Given this list of marker genes Rack1, Mfsd4b1, Ap2a2, Aplp2, Rplp1, Acsl5 (NCBI Gene Id 71879), Lmo4, Flvcr1, Lgals3, H2aj, Rpl39, Actn4 (actinin alpha 4), Dynlt3, Tomm6, Pdia3, Pth1r, Tmem176a, Rps19, Ptprf, Adgrg1, C130074G19Rik (NCBI Gene Id 226777), Ube2d3, Cyfip2, Rpl12, Fth1 (NCBI Gene Id 14319), Fgf1, Pgk1, Rpl31-ps12, Rpl5, Gng12, Hoxb9, Pdcd4, Stat3, Wsb1, Bmp4, Pmepa1, Mal (myelin and lymphocyte protein, T cell differentiation protein), H2-K1, Tmbim6, Serp1, Foxq1, Pdia6, Dstn, Sh3bgrl3, Eva1b, Atp6v0a4, Entpd4, Rbm47, Spink1, Actb, Gls, Mfge8, Ly6c1, Tmem178, Gas6, Dynll1, Bbln, Ggt1, Tmprss2, Arpc2, Tle5, Kif5b, Ost4, Msi2, Plekhb2, Klhdc8a, Clu, Cldn16, Rhoa, Ivns1abp, Tfcp2l1, Rnasek, Pigr, Nucks1, Rbm3, Ndrg1, Slc5a1, Anxa5, Rps28, Man2a1, Rpl10, Gipc2, Calm1, Calr, Gstt1, Mapre1, Hpcal1, B2m, Car15, Cd9, Cnbp, Canx, Sec14l1, Dync1i2, Mlf2, Cttn, Raly, Ablim1, Rps20, Itm2c, Atp6v1g1, Rpl29, Eif4g2, Stx7, Rpl4, Cltb, Sh3bgrl (SH3-binding domain glutamic acid-rich protein like), Rogdi, Stk39, Rab6b, Abhd17c, H2-D1, Cd2ap, Tpt1, Ctsd, Nuak2, Chmp3, Cfl1, Cd74, Slc25a17, Eef1a1, H2-Eb1, Hoxd9, Kctd1, Tceal9, Clcnkb, Sfrp1, Eif5, Cxcl16, Rpl21, Eprn, Ywhab, Acly, Atp6v1a, Rps7, Scp2, Spp1, Ppp2r3a, Flrt1, Ftl1, Kap, Sec61g, Prr13, Rpl6 (NCBI Gene Id 19988), Gpx3, Uqcc2, Rps13, Aif1l, Rps23, Dnajc3 (NCBI Gene Id 19107), Selenow, Gpx4, Napsa, Slc25a39, Ubxn2a, Dusp3 (dual specificity phosphatase 3 (vaccinia virus phosphatase VH1-related)), Erdr1, Rpl22, Wnk1, Zfp36l1, Klk1, Miox, Eif5a, Ppm1h, Tmem254, Hnrnpa3, Tmem176b, H2-Ab1, Tnfaip2, Srrm2, Atp6v1f, Smad7, Pkp4, Gpx1, Rab5c, Ybx1, Rps12 (NCBI Gene Id 20042), Tesc, Chp1, 4833439L19Rik, Atp4a, Rragd, Tacc2, Fgf9 (fibroblast growth factor 9), Mt2, Bola3, Selenom, Tcf25, Tubb2b, Timp3, Nenf, Ptp4a2, Emb, Capns1, Kif1b, Tspan33, Tmsb4x, Rps4x, Sardh, Pts (6-pyruvoyl-tetrahydropterin synthase), Rpl38, Tmem52b, Rab18, Tmsb10, Kcnj16, Umod, Gsr, Gnb1, Scnn1a, Acsl4, Tspan1, Ly6e, Lpp, Wfdc2, Akr1a1, Prkar1a, Rpn2, Stub1, Efhd1, Apoe, here is a description of the gene set: species: Mus musculus from publication Tabula Muris Consortium (PMID 32669714) Mouse Gene Set: TABULA_MURIS_SENIS_KIDNEY_KIDNEY_LOOP_OF_HENLE_THICK_ASCENDING_LIMB_EPITHELIAL_CELL_AGEING